The following is a description of a gene set: Catalysis of the reaction: ATP = pppA(2'p5'A)n oligomers. This reaction requires the binding of double-stranded RNA. Mouse Gene Set: GOMF_2_5_OLIGOADENYLATE_SYNTHETASE_ACTIVITY species: Mus musculus, and this is the list of marker genes: Oas1h, Oas1e, Oas1d, Oas2, Oasl2, Oas1g, Oas1b, Oas1c, Oas1f, Oasl1, Oas1a, Oas3